The following is a description of a gene set: Mouse Gene Set: MIR_3059_3P studied in species Mus musculus from publication Chen Y, Wang X (PMID 31504780) Genes predicted to be targets of miRBase v22 microRNA mmu_miR_3059_3p in miRDB v6.0 with MirTarget v4 prediction scores > 80 (high confidence targets)., and this is the list of marker genes: Itch (itchy, E3 ubiquitin protein ligase), Tecpr2, Fyb1, Dcun1d4, Papolb, Rela, Cenpo, Mex3a, Catsperz, Erlin1, Ptpmt1, Fzd6, Dnah5, Ihh, Mmp16, Megf9, Cyp3a13, Tox, Khdrbs1 (NCBI Gene Id 20218), Naa35, 4833439L19Rik, Me1, Pcp4, Serpind1, Alg10b, Oxsr1, Slc22a23, Chek1, Scn7a, Ppp2r5a, Zbtb17, Eef1b2